The following is a description of a gene set: The series of events that restore integrity to damaged tissue that contribute to an inflammatory response. studied in species Homo sapiens Human Gene Set: GOBP_WOUND_HEALING_INVOLVED_IN_INFLAMMATORY_RESPONSE, and this is the list of marker genes: HMOX1, TIMP1, PPARG, MIR17, HIF1A, IL1A, AGER, F2R, TLR4, TGFB1